The following is a description of a gene set: Reactome Pathway: PI3K events in ERBB2 signaling species: Mus musculus electronically inferred by orthology from the curated human pathway part of: Signaling by ERBB2 This event has been computationally inferred from an event that has been demonstrated in another species.<p>The inference is based on the homology mapping from PANTHER. Briefly, reactions for which all involved PhysicalEntities (in input, output and catalyst) have a mapped orthologue/paralogue (for complexes at least 75% of components must have a mapping) are inferred to the other species., and this is the list of marker genes: Erbb2, Btc, Nrg3, Gab1, Grb2, Egfr, Erbb4